The following is a description of a gene set: from publication Chen Y, Wang X (PMID 31504780) species: Mus musculus Genes predicted to be targets of miRBase v22 microRNA mmu_miR_8104 in miRDB v6.0 with MirTarget v4 prediction scores > 80 (high confidence targets). Mouse Gene Set: MIR_8104, and this is the list of marker genes: Dcaf12, Bptf, Mex3c, Slc45a3, Dut, Arhgap12, Serpinb6c, Stag1, Alox15, Dhrs7b, Sema3a, Mcidas, Psd3, Babam1, Cimip2b, Sugct, Med1, Pcnx1, Bfar, Brdt, Sec61a2, Tnpo2, Col5a2, Btaf1, Lin52, Usp44, Armcx3, Sema5a, Rsph4a, Vcl, Ccp110, Ly6i, Lrrtm3, Mkx, Elavl2, Sftpa1, Odr4, S1pr2, Stim1, Ptpn3, Poln, Asb5, Blcap